The following is a description of a gene set: Decreased facial expression studied in species Homo sapiens Human Gene Set: HP_DECREASED_FACIAL_EXPRESSION A reduced degree of voluntary and involuntary facial movements involved in responded to others or expressing emotions., and this is the list of marker genes: LARGE1, TK2, DDHD2, ACTA1, SLC9A7, MYH2, CCDC174, PAX6, TECPR2, PLAA, NOTCH2NLC (NCBI Gene Id 101060315), SLC6A8, TNPO2, ATP6V1A, GMPPB, TH, GLE1, PYROXD1, DMXL2, SPTBN4, ITGA7, FKRP, PLXND1, UBE3A, SLC6A9, POMT2, TAFAZZIN, SPR, CERT1, SMCHD1, MSTO1, RYR1, DUX4L1, RRM2B, DNAJC6, FBXO7, ERGIC1, BCL11B, ATP13A2, COL25A1 (collagen type XXV alpha 1 chain), SLC6A3, UBA1, FRG1, VPS41, MYH3, PTRHD1, ITPR1, PRNP (NCBI Gene Id 96713), KCNK9, ASXL3, MYH7, GFM2, HACD1, RIPK4, NEUROG1, PIGA, PLA2G6, ATP7A, FTL, TANGO2, SLC25A4, STAC3, ATXN3, SYNJ1, SCYL2, SLC39A14, GBA1 (glucosylceramidase beta 1), PABPN1 (NCBI Gene Id 8106), SNCAIP, EBF3, MAP3K20, CRELD1, LRRK2, SLC30A10, KNSTRN, TBP, LRP12, FKTN, GIGYF2, SLC16A2, DNA2, PIEZO2, TWNK, ATP6AP2, SLC20A2, KCNJ6, TPM3, PDGFRB, VAMP1, ADH1C, LAMA2, PANK2, HOXB1 (homeobox B1), DCTN1, NR4A2, TNNT1, PRDX3, POLG, SLC18A2, ATXN8OS, ATP1A3, KLHL41, JAM2, CC2D1A, MYL1, SELENON, MT-TT, DUX4, POMT1, POLG2, TRIM32, ATXN2, UFC1 (NCBI Gene Id 51506), EIF4G1 (NCBI Gene Id 1981), PTRH2, MYL2, UBA5, CLTC, EIF2AK2, HLA-DQB1 (NCBI Gene Id 7924), PDGFB, DLK1, MAPT, TBCK, PURA, FA2H, MEG3, NEB, GOSR2, RILPL1, ATCAY, KCNH1, REV3L, FMR1, SGCB, PODXL, TPM2, MYMX, SNCA, PIK3CD, HSPG2, RTL1, SLC52A3, DNAJC13, MRE11, GIPC1, DPM2, CNTNAP1, VPS35, TXNL4A, DNMT3B